The following is a description of a gene set: Coronaviruses (CoVs) are positive-sense RNA viruses that replicate in the interior of double membrane vesicles (DMV) in the cytoplasm of infected cells (Stertz S et al. 2007; Knoops K et al. 2008). The viral replication and transcription are facilitated by virus-encoded non-structural proteins (SARS-CoV-1 nsp1–nsp16) that assemble to form a DMV-bound replication-transcription complex (RTC). The replication strategy of CoVs can generate both single-stranded RNA (ssRNA) and double-stranded RNA (dsRNA) species, that may act as pathogen-associated molecular patterns (PAMPs) recognized by pattern recognition receptor (PRR) such as toll-like receptor 7 (TLR7) and TLR8, antiviral innate immune response receptor RIG-I (also known as DEAD box protein 58, DDX58) and interferon-induced helicase C domain-containing protein 1 (IFIH1, also known as MDA5) (Cervantes-Barragan L et al. 2007; Chen Y et al. 2009, 2011; Daffis S et al. 2010; Li Y et al. 2013). The activated PRRs trigger signaling pathways to produce type I and type III interferons IFNs and proinflammatory mediators that perform antiviral functions. First, endosomal recognition of viral ssRNA occurs by means of TLR7 and TLR8 which detect GU-rich ssRNA sequences. Specifically, GU-rich ssRNA oligonucleotides derived from SARS-CoV-1 stimulated mononuclear phagocytes to release considerable levels of pro‑inflammatory cytokines TNF‑a, IL‑6 and IL‑12 via TLR7 and TLR8 (Li Y et al. 2013). Second, SARS-CoV-1 dsRNA replication intermediates can be recognized by cytoplasmic receptors DDX58 and IFIH1 which bind to mitochondrial antiviral-signaling protein (MAVS, IPS-1) to induce the IFN-mediated antiviral response. In addition, the module shows an antiviral function of interferon-induced protein with tetratricopeptide repeats 1 (IFIT1) that directly binds and sequesters viral single-stranded uncapped 5′-ppp RNA and cap-0 RNA (Daffis S et al. 2010). This module also describes several strategies developed by SARS-CoV-1 to evade or alter host immunity, including escaping innate immune sensors, inhibiting IFN production and signaling, and evading antiviral function of IFN stimulated gene (ISG) products. For example, viral dsRNA replication intermediates derived from SARS‑CoV‑1 were shown to associate with RTC bound to double membrane vesicles, which protected viral RNA from sensing by DDX58 or IFIH1 (Stertz S et al. 2007; Knoops K et al. 2008). Further, SARS-CoV-1 encodes nsp14 and nsp16 which possess guanine-N7-methyltransferase activity and 2’-O-methyl-transferase activity respectively (Chen Y et al. 2009, 2011). SARS-CoV-1 nsp14 generates 5' cap-0 viral RNA (m7GpppN, guanine N7-methylated) and nsp16 further methylates cap-0 viral RNA. These viral RNA modifications mimic the 5'-cap structure of host mRNAs allowing the virus to efficiently evade recognition by cytosolic DDX58 and IFIH1 (Chen Y et al. 2009, 2011; Daffis S et al. 2010). The nsp16-mediated ribose 2′-O-methylation of viral RNA also blocks the antiviral function of IFIT1 complexes (Menachery VD et al. 2014). Further, the uridylate‐specific endoribonuclease (EndoU) activity of viral nsp15 degrades viral RNA to hide it from innate immune sensors (Bhardwaj K et al. 2006; Ricagno S et al. 2006). Moreover, SARS-CoV-1 encodes several proteins that directly bind to host targets associated with SARS‑CoV‑1 infection and cytokine production (Frieman M et al. 2009; Hu Y et al. 2017; Kopecky-Bromberg SA et al. 2007; Lindner H et al. 2005; Siu KL et al. 2009). For example, as a de-ubiquitinating enzyme, viral nsp3 binds to and removes polyubiquitin chains of signaling proteins such as TRAF3, TRAF6, STING, IkBA, and IRF3 thereby modulating the formation of signaling complexes and the activation of IRF3/7 and NFkappaB (Sun L et al. 2012; Chen X et al. 2014; Li SW et al. 2016). This inhibits IFN production downstream of TLR7/8, DDX58, IFIH1, MAVS and STING signaling pathways. Binding of SARS-CoV-1 nucleocapsid (N) protein to E3 ubiquitin ligase TRIM25 inhibits TRIM25-mediated DDX58 ubiquitination and DDX58-mediated signaling pathway (Hu Y et al. 2017). Next, SARS‑CoV‑1 membrane (M) protein targets IBK1/IKBKE and TRAF3 to prevent the formation of the TRAF3:TANK:TBK1/IKBKE complex and thereby inhibits TBK1/IKBKE‑dependent activation of IRF3/IRF7 transcription factors downstream of DDX58, IFIH1 and adaptor MAVS (Siu KL et al. 2009; 2014). The ion channel activities of open reading frame 3a (orf3a or 3a) and E contribute to activation of the NLRP3 inflammasome leading to highly inflammatory pyroptotic cell death (Nieto‑Torres JL et al. 2015; Chen IY et al. 2019; Yue Y et al. 2018). Viral 3a promoted the NLRP3-mediated formation of PYCARD (ASC) speck by interaction with both TRAF3 and PYCARD (ASC) (Siu KL et al. 2019). Binding of 3a to caspase-1 (CASP1) enhanced CASP1-mediated cleavage of interleukin 1 beta (IL‑1β) downstream of the NLRP3 inflammasome pathway (Yue Y et al. 2018). Like 3a, SARS-CoV-1 8b was found to bind to NLRP3 activating the NLRP3 inflammasome and triggering IL‑1β release (Shi CS et al. 2019). 8b was also shown to bind IRF3, inhibiting subsequent IRF3 dimerization. At the plasma membrane, binding of SARS-CoV-1 7a to host BST2 disrupts the antiviral tethering function of BST2 which restricts the release of diverse mammalian enveloped viruses (Taylor JK et al. 2015). SARS-CoV-1 9b (orf9b) inhibits the MAVS-mediated production of type I IFNs by targeting TOMM70 on the mitochondria (Jiang HW et al. 2020). SARS-CoV-1 6 (orf6) inhibits the IFN signaling pathway by tethering karyopherins KPNA2 and KPNB1 to the endoplasmic reticulum (ER)/Golgi intermediate compartment (ERGIC) and thus blocking the KPNA1:KPNB1-dependent nuclear import of STAT1 (Frieman M et al. 2007). Binding of SARS-CoV-1 nsp1 to peptidyl-prolyl isomerases (PPIases) and calcipressin-3 (RCAN3) significantly activates the cyclophilin A/NFAT pathway, ultimately enhancing the induction of the IL-2 promoter. At last, SARS‑CoV‑1 3b, after translocating to the nucleus, binds to transcription factor RUNX1 and increases its promoting activity. part of: SARS-CoV-1-host interactions species: Homo sapiens Reactome Pathway: SARS-CoV-1 activates/modulates innate immune responses, and this is the list of marker genes: RCAN3, PPIH, S, TKFC, rep, BST2, IRF3, N, TLR7, CASP1, E, UBC, 3b, 9b, 7a, TRAF6, TBK1, RIGI, PYCARD, KPNA2, PPIB, MAVS, NPIPB3, 8b, IFIH1, NFKB1, ITCH, PPIG, PCBP2, IKBKE, TRAF3, NFKBIA, SFTPD, SIKE1, FKBP1A, 3a, NMI, SARS coronavirus, complete genome, TRIM25, RELA, TOMM70, M, NLRP3, UBB, UBA52, 1a, STING1, IRAK2, KPNB1, RUNX1, 6, RPS27A, PPIA, RIPK3